The following is a description of a gene set: The chemical reactions and pathways involving melanins, pigments largely of animal origin. High molecular weight polymers of indole quinone, they are irregular polymeric structures and are divided into three groups: allomelanins in the plant kingdom and eumelanins and phaeomelanins in the animal kingdom. species: Mus musculus Mouse Gene Set: GOBP_MELANIN_METABOLIC_PROCESS, and this is the list of marker genes: Pmel, Slc45a2, Bcl2, Ctns, Atp7a (NCBI Gene Id 51824), Cited1, Myo5a, Vhl, Mc1r, Oca2, Wnt5a, Gipc1, Opn3, Appl1, Trpc1, Tyr, Rab38, Slc24a5, Zeb2, Rapgef2, Mfsd12, Dct, Ddt, a, Cdh3, Slc7a11, Tyrp1